The following is a description of a gene set: Skin characterized by the lack of natural or normal moisture. Dry skin studied in species Homo sapiens Human Gene Set: HP_DRY_SKIN, and this is the list of marker genes: KANSL1, DDB2, ADAR, IDH1, GSN (gelsolin), CD28, PRKD1, ALOXE3, CST6, FLG2, TNFRSF1B, NTRK1, AARS1, LSM11, PEX11B, MPDU1, SULT2B1, SATB1, GJB4, RNASEH2A, BRAF, XPC, OFD1 (NCBI Gene Id 8481), KDSR, ABCA1, GNB2, RALGAPA1 (NCBI Gene Id 387984), NLRP1, PGM2L1, LETM1, TRIP4, RAP1B, CHD7, ALK (ALK receptor tyrosine kinase), IL7R, ARNT2, POLH, TARS1, RAG1, MAP2K1, SAMHD1, DCLRE1C (DNA cross-link repair 1C), ZNF341, POT1, PIGG, RNASEH2C, MAPK1, CSTB, OTX2, SLC5A5, GJB3, ALG11, CDKN2A, RIPK4, NSD2, IFIH1 (interferon induced with helicase C domain 1, NCBI Gene Id 64135), RNU4ATAC, NFKBIA, ALDH3A2, KIF11, MC1R, TINF2, CAST, NSUN2, BCKDK, POLR3A, CPLX1, ERCC4, WNT10A, NKX2-5, ACD, SOX5, KCTD1, ERCC5, TRH, GNA11, NOD2, EDA, CLDN1, ADA, LIPN, SRD5A3, RYR1, SMG8 (NCBI Gene Id 55181), RNF113A, RMRP, CARS1, STS, CDKN2B, GABBR1, MAP2K2, TWIST2, GTF2H5, TSHB, EDARADD, FLG, SDR9C7, SLF2, NELFA, SKIC3, SOX3, KRAS, TGM1, DPP9, XPA, PCNT, CAMK2B (NCBI Gene Id 816), RNU7-1, ABCA12, POLD3, MPLKIP, RAG2, NAGA, MYSM1, GINS1, TRPM1, PAX8, TP63, HESX1, GTF2E2, NRAS, BANF1, UVSSA, FOSL2, CAV1, PAH, FGFR1, LIG4 (DNA ligase 4), RAF1, OSMR, KRT14, BAP1, TTC5, RNASEH2B, KIF15, PEX7, KRT1, EDAR, DBR1, CLDN10, RNF168, PHYH, TERF2IP, CTLA4, ERCC2, PEPD, PTPN11, KYNU, ERCC6, COG6, CTBP1, DOLK, CASR, IFT43, ERCC3, PIGH, ELOVL4, INSR, DRG1, RECQL, THRA, FDFT1, UBE2A, TRHR, FUCA1, ALOX12B, ZEB2, ATP7A, DDOST, SPEN, TREX1, GPNMB, WNT10B, ODC1, PPP2R3C, MGMT, SMARCAD1, SKIC2, PROKR2, SOX2, NOTCH2, TERT, CYP4F22, MITF, GJA1, IL2RG, ELOVL1, MBTPS2, SPRED2, SLC39A4, NIPAL4, EXOC2, PIGL, SASH1, SPINK5, ASPRV1, ERCC8, CDK4